The following is a description of a gene set: from publication Kim HK, Choi IJ, Kim HS, Kim JH, Kim E, Park IS, Chun JH, Kim IH, Kim IJ, Kang HC, Park JH, Bae JM, Lee JS, Park JG (PMID 15033468) studied in species Homo sapiens Human Gene Set: KIM_GASTRIC_CANCER_CHEMOSENSITIVITY The mechanisms of intrinsic and/or acquired anti-cancer drug resistance have been described in in vitro resistance models, but the clinical relevance has remained undefined. We undertook a prospective study to identify correlations between gene expression and clinical resistance to 5-FU/cisplatin. We compared expression profiles from gastric cancer endoscopic biopsy specimens obtained at a chemosensitive state (partial remission after 5-FU/cisplatin) with those obtained at a refractory state (disease progression), using Affymetrix oligonucleotide microarray technology (U133A). Using 119 discriminating probes and a cross-validation approach, we were able to correctly identify the chemo-responsiveness of 7 pairs of training samples and 1 independent test pair. These exploratory data demonstrate that the gene expression profiles differ between chemosensitive and refractory state gastric cancer biopsy samples. Genes up-regulated in gastric cancer patients refractory to chemotherapy treatment with 5-fluorouracil and cisplatin compared to the sensitive state., and this is the list of marker genes: SLCO2B1, ALG3 (NCBI Gene Id 131416), CRTC1, B3GAT3, EIF2B4, FABP7, PSRC1, WDR55, RAB2A, CRYBB2 (NCBI Gene Id 879), MYO7A, HHLA1, NME4, MEF2D, DES, NENF, HEATR6, KDM4B, TNMD, NCR3, POLG, NPAP1, SCNN1A, BARX1, SLC13A2, CHKA, GOLGA8A, DCAF8, SGTA, MOCS3, POLR1E, PPP1R12B, OBP2A, PPFIA3, ADAMTS8, BORCS6, ZNF219, FKBP8, N4BP2L1, EPO, TNNI2, MTARC1, ITGB1BP2, EHMT2, OMP, PPFIA1, TMEM151B, DPAGT1, GLYR1, RPL13A, CCL17, BCL2, TARS2, TSR1, AATK, NCAM1, SLURP1 (secreted LY6/PLAUR domain containing 1), MAPKAPK3, EPHB1, TSHZ2, SLC26A6, IFRD2, MPZL1, BAIAP2, IL1R1, TADA2A, POLR2A, PPP2R1A, MR1, ACVR1B, SLC11A2, MYL10, RGR, ARMC6, LDB1, ABO, PHGDH, DOHH, ELK4, ECT2, IL12RB1, FOXD4, UNG, ABCB8, TMEM8B, RAB27B, NIPAL2, ANGEL1, NEK9, SMG1P2, CFAP410, PLXNB1, ADCY3, DTX2P1-UPK3BP1-PMS2P11